Given this list of marker genes NEDD4L, MIR24-1, PCSK9, STK39, MIR448, here is a description of the gene set: Human Gene Set: GOBP_REGULATION_OF_SODIUM_ION_IMPORT_ACROSS_PLASMA_MEMBRANE studied in species Homo sapiens Any process that modulates the frequency, rate or extent of sodium ion import across the plasma membrane.